Given this list of marker genes BRF1, PCNT, SBDS, RSPRY1, SRP54, RET, BMP4, DNAJC21, EFL1, here is a description of the gene set: Slipped capital femoral epiphysis is defined as a posterior and inferior slippage of the proximal epiphysis of the femur onto the metaphysis (femoral neck), occurring through the physeal plate during the early adolescent growth spurt. Proximal femoral epiphysiolysis Human Gene Set: HP_PROXIMAL_FEMORAL_EPIPHYSIOLYSIS studied in species Homo sapiens